The following is a description of a gene set: studied in species Homo sapiens Any process that activates or increases the frequency, rate or extent of activity of the transcription factor CREB. Human Gene Set: GOBP_POSITIVE_REGULATION_OF_CREB_TRANSCRIPTION_FACTOR_ACTIVITY, and this is the list of marker genes: RPS6KA5, RPS6KA4, EPHA5, CRTC2, CAMK1D (calcium/calmodulin dependent protein kinase ID), CRTC1, ADCY1, SYT14P1, ADCY8, TSSK4